The following is a description of a gene set: Severely slow or limited growth after birth, being four standard deviations or more below age- and sex-related norms. Human Gene Set: HP_SEVERE_POSTNATAL_GROWTH_RETARDATION Severe postnatal growth retardation species: Homo sapiens, and this is the list of marker genes: TBC1D20, PTPN2, BRD4, NIPBL, TAF6, PRIM1, INSR, CTBP1, EBP, CD247, BLM, GATA3, RNU4ATAC, LETM1, HDAC8, IL2RA, ANKRD55, ERCC8, STAT4, EMG1, NSD2, TSHB, LHX4, IL2RB, FGFRL1, RYR1, NIN, TRMT10A, RAD21 (NCBI Gene Id 5885), POU1F1, PPP1R15B, GNPTAB, RPL10, PTPN22, IGF1, SMC1A, SMC3, CPLX1, WFS1, SHPK